Given this list of marker genes Nmrk2, Nmnat2, Nmrk1, Pnp, Slc25a51, Pnp2, here is a description of the gene set: Mouse Gene Set: GOBP_PYRIDINE_NUCLEOSIDE_METABOLIC_PROCESS species: Mus musculus The chemical reactions and pathways involving any pyridine nucleoside, a nucleoside in which a pyridine base covalently bonded to a sugar, usually ribose.